The following is a description of a gene set: from publication Elvidge GP, Glenny L, Appelhoff RJ, Ratcliffe PJ, Ragoussis J, Gleadle JM (PMID 16565084) Genes up-regulated in MCF7 cells (breast cancer) under hypoxia conditions. Human Gene Set: ELVIDGE_HYPOXIA_UP Studies of gene regulation by oxygen have revealed novel signal pathways that regulate the hypoxia-inducible factor (HIF) transcriptional system through post-translational hydroxylation of specific prolyl and asparaginyl residues in HIF-alpha subunits. These oxygen-sensitive modifications are catalyzed by members of the 2-oxoglutarate (2-OG) dioxygenase family (PHD1, PHD2, PHD3, and FIH-1), raising an important question regarding the extent of involvement of these and other enzymes of the same family in directing the global changes in gene expression that are induced by hypoxia. To address this, we compared patterns of gene expression induced by hypoxia and by a nonspecific 2-OG-dependent dioxygenase inhibitor, dimethyloxalylglycine (DMOG), among a set of 22,000 transcripts, by microarray analysis of MCF7 cells. By using short interfering RNA-based suppression of HIF-alpha subunits, we also compared responses that were dependent on, or independent of, the HIF system. Results revealed striking concordance between patterns of gene expression induced by hypoxia and by DMOG, indicating the central involvement of 2-OG-dependent dioxygenases in oxygen-regulated gene expression. Many of these responses were suppressed by short interfering RNAs directed against HIF-1alpha and HIF-2alpha, with HIF-1alpha suppression manifesting substantially greater effects than HIF-2alpha suppression, supporting the importance of HIF pathways. Nevertheless, the definition of genes regulated by both hypoxia and DMOG, but not HIF, distinguished other pathways most likely involving the action of 2-OG-dependent dioxygenases on non-HIF substrates. species: Homo sapiens, and this is the list of marker genes: GJA1, PLAC8, BNIP3L, AHNAK2, ASPH, DUSP1, ZNF292, ZNF395, S100A4, DPYSL4, LOXL2, SRPX, CCN1, INSIG2 (NCBI Gene Id 51141), SCARB1, OBSL1, FAM216A, BCOR, ANKZF1, GYS1, KLF6, CD59, NR3C1, SPRY1, FAM13A, EGR1, QSOX1, GPR87, ECE1, DAAM1, ELF3, ENO2, VEGFA, PIM1, HCFC1R1 (host cell factor C1 regulator 1), ATXN1, CCNG2, TXNIP, KRT7, SRD5A3, BNIP3, YEATS2, RNASE4, DSC2, RRAGD, ARTN, S100A6, KLF7 (KLF transcription factor 7), RBCK1, WSB1, NOL3, TBC1D3F, FOS, BBX, STC2, MXI1, PDK1, TGFBI, GUSBP14, HK2, EGLN3, CADM1, SFXN3, ILVBL, FYN, ADGRE2, ISG20, LIMCH1, KDM3A, INHA, GADD45B, ADORA2B, GDF15, IGFBP3, ITPR1, SORL1, GLRX, EGFR, ERO1A, PFKP, P4HA2, ZNF654, YPEL1, NAP1L1, ANGPTL4, DPYSL2, SAMD4A, EFNA3, CYP1B1, DDR1, PFKFB3, ALDOC, CSRP2, RLF, KDM4B, GBE1, RASA4, SPOCK1 (NCBI Gene Id 6695), NREP, CSGALNACT1, CAV1, CXCR4, SAT1, CEMIP, ORAI3, B3GNT4, PDGFB, MAFF, FLNB, ATF3, HILPDA, IGFBP5, BHLHE40, PPFIA4, UPK1A, PAM, MT-ND5, STC1, ENSG00000301105, EGLN1, PGM1, VEGFC, SOX9, ADM, HLA-DRB1, PLAUR, HEY1, TIPARP, MET, TNFAIP8, SLCO4A1, DDIT4, STBD1, PXDN, P4HA1, DST, RBPJ, CYB5A, SH3GL3, PGK1, OPN3, CITED2, NDRG1, KRT15, ZMYND8, AKAP12, LOX, DTNA, GPRC5A, PDGFRL, OLFML2A, S100A2, ATG14, TMEM265, SPAG4, ANG, SERPINE1, CCN5, SCNN1B, LOXL1, CAVIN1, TMEFF1, AK4, KLHL24, VLDLR (NCBI Gene Id 7436), JUN, SLC2A1, PGAP1, PRKCA, TMEM45A, NFIL3, CA9, PLIN2, FAM162A